The following is a description of a gene set: studied in species Mus musculus A synapse of a granule cell fiber onto the dendrites of a Purkinje cell in cerebellum. Mouse Gene Set: GOCC_CEREBELLAR_GRANULE_CELL_TO_PURKINJE_CELL_SYNAPSE, and this is the list of marker genes: Grid2ip, Chd4, Cntnap2, Ywhah, Grm4, Ogt, Elavl2